Given this list of marker genes VPS41, TAF2, ANKRD46, FBXW11, RB1CC1, NAPG, CHD7, PPFIA1, MFN1, ING1, PEPD, BRWD1, FIG4 (NCBI Gene Id 9896), DCTD, MRPS11, PDCD6, NSD3, KRIT1, GZF1, MRPS28, ZNF302, PNPT1, PHC3, FXR1, SIAH2, NDUFB5 (NADH:ubiquinone oxidoreductase subunit B5), ARMC8 (armadillo repeat containing 8), WASHC5, TRIM35, PPM1A, ATP11B, PAK2, NIPBL, CTTN (cortactin), MAP3K1 (mitogen-activated protein kinase kinase kinase 1), CDK8, PPP4R2, TBCA, RYK, DNAJC2, NEK3, KBTBD11, MIPEP, URI1, TPD52, AKAP9, PAN3, LSM1, GTF3A, SDHC, ASH2L, DBR1, RFC4, METTL4, GABPA, MTMR6, CBLL1, IPO8, TERF1, KPNA4, ARMC1, MACROH2A1, ANKRD10, BAG4, E2F3, THUMPD1, NUP153, GOLGA7, TXNL1, SEC23IP, C19orf12, PRKCI, MAPK8, RAE1, DCAF13, FAM91A1, GATAD1, FBXO25, FBXO3, BRMS1L, PPP1R12A, TOMM70, RASA1, PIK3CA, EID2, COG5, MRPL47, MYNN, FBXO33, COG3, VPS8, SENP2, CEBPG, CMAS, SNAP29, THOC1, RAB20, EIF3H, GEMIN2, CDC42SE2, here is a description of the gene set: Human Gene Set: DING_LUNG_CANCER_EXPRESSION_BY_COPY_NUMBER studied in species Homo sapiens The lung adenocarcinoma TSP (tumor sequencing project) genes showing strong correlation between DNA copy number variation and gene expression. from publication Ding L, Getz G, Wheeler DA, Mardis ER, McLellan MD, Cibulskis K, Sougnez C, Greulich H, Muzny DM, Morgan MB, Fulton L, Fulton RS, Zhang Q, Wendl MC, Lawrence MS, Larson DE, Chen K, Dooling DJ, Sabo A, Hawes AC, Shen H, Jhangiani SN, Lewis LR, Hall O, Zhu Y, Mathew T, Ren Y, Yao J, Scherer SE, Clerc K, Metcalf GA, Ng B, Milosavljevic A, Gonzalez-Garay ML, Osborne JR, Meyer R, Shi X, Tang Y, Koboldt DC, Lin L, Abbott R, Miner TL, Pohl C, Fewell G, Haipek C, Schmidt H, Dunford-Shore BH, Kraja A, Crosby SD, Sawyer CS, Vickery T, Sander S, Robinson J, Winckler W, Baldwin J, Chirieac LR, Dutt A, Fennell T, Hanna M, Johnson BE, Onofrio RC, Thomas RK, Tonon G, Weir BA, Zhao X, Ziaugra L, Zody MC, Giordano T, Orringer MB, Roth JA, Spitz MR, Wistuba II, Ozenberger B, Good PJ, Chang AC, Beer DG, Watson MA, Ladanyi M, Broderick S, Yoshizawa A, Travis WD, Pao W, Province MA, Weinstock GM, Varmus HE, Gabriel SB, Lander ES, Gibbs RA, Meyerson M, Wilson RK (PMID 18948947) Determining the genetic basis of cancer requires comprehensive analyses of large collections of histopathologically well-classified primary tumours. Here we report the results of a collaborative study to discover somatic mutations in 188 human lung adenocarcinomas. DNA sequencing of genes with known or potential relationships to cancer revealed more than 1,000 somatic mutations across the samples. Our analysis identified genes that are mutated at significantly high frequencies and thus are probably involved in carcinogenesis. The frequently mutated genes include tyrosine kinases, among them the EGFR homologue ERBB4; multiple ephrin receptor genes, notably EPHA3; vascular endothelial growth factor receptor KDR; and NTRK genes. These data provide evidence of somatic mutations in primary lung adenocarcinoma for several tumour suppressor genes involved in other cancers--including NF1, APC, RB1 and ATM--and for sequence changes in PTPRD as well as the frequently deleted gene LRP1B. The observed mutational profiles correlate with clinical features, smoking status and DNA repair defects. These results are reinforced by data integration including single nucleotide polymorphism array and gene expression array. Our findings shed further light on several important signalling pathways involved in lung adenocarcinoma, and suggest new molecular targets for treatment.